Given this list of marker genes PLP2 (proteolipid protein 2), PTPN1, SNU13, ETV1, PSMD8, NBR2, CHRNA5, IL13, S1PR1, HILPDA, NAT8, AKR1C2, OR2W1, CDK18 (NCBI Gene Id 5129), DUS4L, CDKN1A, PHC2, RPS3A, RPL31, DOK5, SEMA4D, RPS2, ZNF133, PTPRD (NCBI Gene Id 5789), RRAGD, SEPTIN10, ATP6V1C1, ADD1, TPM1, NDUFV2, PKIG, MSI1, PHAF1, TDP1, WNT16, CYB5R4, HAGH, SNX16, PREPL, NDFIP1, CD53, TP53BP2, MEA1, KCNJ15 (potassium inwardly rectifying channel subfamily J member 15), TMEM120B, MGAM, ST13, S100A2, TMEM156, CD68, HMGB3P30, GTF3C4, ABCC9, DUSP1, ST8SIA1, C14orf93, COCH, SLC38A2, DCAF1, BCKDK, LRP1B, SLC52A1, SOS2, TFDP2, SOD2, LPCAT3, MACF1, COMT (NCBI Gene Id 1312), HYAL3, GPR50, MYOM2, TENM1, JUN, RPA4, TFCP2 (transcription factor CP2), BRCA2, MTX2, LRFN3, SYNGR1, DSTNP2, RBP4, H4C8, FGF7, TMSB10 (NCBI Gene Id 9168), TCEAL2, COG5, RPP30 (ribonuclease P/MRP subunit p30), H2BC11, GLO1, CD163, RPL21, SRY, ZNF254, PRKD3, CORO2A, PLCG2, PSTPIP1, CPA3, RPL35, NT5E, RAMP1, TMEM186, SNCA, ACTR2, MIA2, TOM1L1, NPIPA1, KIR2DL4, EP400, WNK1 (WNK lysine deficient protein kinase 1), MCM2 (minichromosome maintenance complex component 2), FLG, CRYZL1, RASA2, GLUL, ADAM19, TUBA3C, AARS1 (NCBI Gene Id 16), OTULINL, PALM, RUNX1T1, LRRTM2, DDX4, SINHCAF, FMO2, RBM4, MED28, CPA2, FXN, RPS14, NKX2-1, TRADD, MLH3, DNMT3B, SLC16A8, SART3, PSMD11, NKX3-2, FEZF2, ADAMTS5, SPO11, ASAP1, FAM149B1, MATN1, ZBBX, CYREN, ING1, KDM4D, KDM2A, SOX14 (NCBI Gene Id 8403), ZNF667, COL19A1, RPS8, NFE2L1, PLEKHO1, SLC30A6, LRRC20, INSM1, MED7, ARID3B, ADAMTS3, CFAP298, VSIG10, PEX26 (peroxisomal biogenesis factor 26), PCCB, TNFRSF21 (NCBI Gene Id 51323), BMPR1A, PERP, RPS17P5, CD300A, GPR107, CEP152, DPPA4, SYNE3, PTPRN2, SPOCK1, PIGC, HOOK2, PRSS16 (serine protease 16), HAPLN1, RIBC2, RAB11FIP2, MXI1, ZNF195, PRRG3, IL9R, OSBPL2, RNF24 (NCBI Gene Id 51262), HSPA9, PPP1R9A, GMIP, VEGFA (vascular endothelial growth factor A), OSGIN2, PIEZO1, ZDHHC4, FAM193B, PRELID3A, LETMD1, NCL, here is a description of the gene set: Human Gene Set: GSE2585_THYMIC_DC_VS_MTEC_UP from publication Derbinski J, Gäbler J, Brors B, Tierling S, Jonnakuty S, Hergenhahn M, Peltonen L, Walter J, Kyewski B (PMID 15983066) Gene expression in different thymic stromal cells and subsets thereof was analyzed in 6-12 week old wild type (C57BL/6) and Aire knock-out (mixed background) mice. Thymic stromal cells were purified by sequential enzymatic digestion (collagenase, collagenase/dispase and trypsin) followed by gradient centrifugation and FACS sorting. Sort criteria were as follows: dendritic cells (CD11c+, F4/80 -), macrophages (F4/80+, CD11c-), cTECs (CD45–/lo, CDR1/Ly51+, Ep-CAM+) and mTECs (CD45–/lo, CDR1/Ly51–, Ep-CAM+). mTECs of wild-type and Aire knock-out mice were further subdivided according to CD80 expression levels. For microarray analysis total RNA from thymic stromal cell samples of two independent experiments was pre-amplified and biotinylated by two rounds of cDNA synthesis and in vitro transcription. Fluorescence readings were evaluated by using Microarray Suite 5.0 software. Genes up-regulated in thymic dendritic cells versus medullary thymic epithelial cells (mTEC). studied in species Homo sapiens